The following is a description of a gene set: Dectin-2 family Human Gene Set: REACTOME_DECTIN_2_FAMILY species: Homo sapiens, and this is the list of marker genes: FCER1G, MUC13, LYN, MUC15, CLEC4C, CLEC4E, MUC7, MUC17, MUCL1, PLCG2, CLEC4D (NCBI Gene Id 338339), MUC21, MUC5AC (mucin 5AC, oligomeric mucus/gel-forming), SYK, MUC4, MUC5B, MUC16, CLEC6A, MUC3A, CLEC10A, CLEC4A, MUC12, MUC20, MUC6, MUC1, FYN